Given this list of marker genes ZNF551, CDH9, FRMD5, BNC2, GALNT7, TAF4B, GAS1, PPP1R10, PDXK, TBL1XR1, GOLPH3L, STAB2, ERGIC1, TPD52, CREB3L2, BRPF3, ZDHHC16, ARID4B, CAMK4, MYCN, RCAN1, AXL, TNRC18, FRA10AC1, DNM1L, UCN2, CBX3, KLF4, SATB2, SUCO, UNC13C, C14orf28 (NCBI Gene Id 122525), ZNF304, S1PR3, FAM83A, ADIPOR2, ADO, MET, MLLT3, NOTCH1, NOTCH2, CDK6, ALG13, E2F5, PAX5, VCL, CPLX2, SLC25A27, ADAM22, OSGIN2, FLOT2, ZNF16, BRINP1, FOXN2, KIAA1217, ABTB3, GP5, DPP3 (dipeptidyl peptidase 3), LILRA1, COL26A1, CNTN2, AGO4, TAF5, RPGRIP1L, ZCCHC17, STX17 (syntaxin 17), GMFB, SIDT1, GABRA3, METAP1, RTL8A, ABR, XBP1, TMEM79, GPR22, MYT1, UHRF2, ZYG11B, ZFHX4, TMEM109, LHX2, TSN, TOB2, SYT1, FGF23, TMEM74, FAM167A, PKP4, SLC27A4, PEA15, WASF1, LDHA, MDM4, SLC44A2, TMEM184B, CDH13, DCAF7, SDK2, SFT2D1, PDGFRA, EML5, EPN2 (epsin 2), ZMYND11, ASB1, BCL2L13, LYST, VAMP2, PRKD1, CLOCK, ARHGAP1, FAM117B, RAD9B, CELF3, FAM76A, SGTA, ELMOD1, NCDN (NCBI Gene Id 23154), STRN3, NUMBL, RAP1GDS1, SIDT2, GLCE, MMAB, DAGLA, MYH9, CA7, DMWD, CNOT6, JAG1 (NCBI Gene Id 3715), TASOR, PEG10, MAP2K1, SLC4A7, GREM2, DGKZ, CUEDC1, PLAG1, THSD4, OAZ2, PLEKHH2, ASB4, PITPNC1, RALGPS1, SSX5, DAAM1, SAR1A, CACNA1E, SHISA7, ZMYM4, ARHGAP26, PLOD1, MPP2, NOS1AP, MTMR10, SNX15, FUT9, TGIF2, TRANK1, ZNF644, NAV3, LGR4, MBLAC1, ANK2, DIXDC1, XPO5, MGAT5B, LMAN2L, ATG4B, PGM1, MCIDAS, FBXO30, ANKS1A, ZDHHC17, ACSL1, SNTB2, AMER1, SURF4, NECTIN1, RDH11, SRPRA, MLLT1, PTGIS, PNOC, MAP7D3, USP31, LIMD2, PACS1, RGS17, EPHA4, CERS6, RAB21, SNX9, CAPN6, SHOC2, TANC2, TPCN2, AHCYL2, HNF4A, TRIM67, ELL2, SEMA4B, PPFIA1 (PTPRF interacting protein alpha 1), ATMIN, KCNK3, NRN1, LIN28B, JAKMIP1, KITLG, EPS15L1, NAV1, ERC1, LMAN1, TPPP, IGF2BP3, IL6R, SEPTIN3, ACBD3, SERPINF2, PPM1A, NSD1, HTR2C, E2F3 (E2F transcription factor 3), FOXP1, OLIG3, CDH4, ANK3, CACNB3, CDC25A (NCBI Gene Id 993), GMNC, CYREN, TMEM164, MEX3C, CCNE2, DPYSL4, PPP1R11, WIPI2, FKBP1B, INA, PPP1R16B, RFX3, SYNJ1, SNX12, RPS6KA4, SLC37A3, LEF1, HCN3, ZNF281, NRIP3, FOXJ2, CHM, NPNT, RELN, PPARGC1B, POGZ, CLCN3, DLL1, FUT8, YTHDC1, CTNND2, ANP32A, ANKRD52, JADE2, UBP1, PDE7B, KDM5D, NCEH1, ALDOA, GPR158, ASIC2, CA10, ATG5, RRAS, RTL6, MTCL2, DNAJC16, ZBTB9, MGAT4A, AKIP1, SHKBP1, SNAI1, FGD6, ISY1, SGPP1, TBCK, BMP3, ZBTB20, CBFA2T3, FAM107A, GINS3, ARHGEF33, ESYT3, RTN4RL1 (reticulon 4 receptor like 1), PURB, CAMTA1, TMEM255A, ADD2, PPP2R3A, ACSL4, TMEM200B, STK38L, TENT5A, CACNA1C, XYLT1, HSPA1B, SMIM15, RPS6KL1, ABCD1, RRAGC, SCN2B, here is a description of the gene set: Human Gene Set: MIR34A_5P from publication Chen Y, Wang X (PMID 31504780) studied in species Homo sapiens Genes predicted to be targets of miRBase v22 microRNA hsa-miR-34a-5p in miRDB v6.0 with MirTarget v4 prediction scores > 80 (high confidence targets).